Given this list of marker genes NDST1, CYTIP, ZNF24, AMIGO2, SELENOP, TSPAN32, LYPD6B, TGIF2, TIMP2, SLFN5, MGAT5, LRRC42, NIPAL1, PTEN, ITM2A, OAZ2, HIPK3, PIK3IP1, SH3PXD2A, TFCP2, UBE3A, SMARCC1, EXT1, SAMD8, AGO2, LIPA, MYB, IGSF23, BCL3, ADCY6, SOX4, LEF1, CYTH3, DUSP10, IKZF1, PTGIR, DLG4, AMER1, MTMR2, REEP1, CSNK1A1, TTC3, CD200, DGKD, TMEM108, USP28, ZBP1, MRPL30, TNS1, LPCAT3, ART4, ST8SIA1, PHF2, LARP4B, RIPOR2, TRIP12, SLC16A10, MARCKS, ACTN1, BCL11B, NUCB2, CALCRL, IL17RB, UBTD2, ATP6V1D, BTF3L4, ARHGAP29, TRPM1, MACO1, RRAGD, CNN3, CDC42EP4, OSBPL9, ZNF281 (NCBI Gene Id 23528), SATB1, GPR146, MTSS1, CAMK4, BEND5, ZNF629, TRIB2, PACSIN1, LDHB, SMO, SFMBT2, SMC6, PALS1, GPCPD1, ZNF22, TCF7, SPRED1, CSRNP2, SPSB1, BACH2 (NCBI Gene Id 653980), PPP1R3B, CHST15, GPRC5B, UBE2E2, GNB4, CD81, FOXP1, PLEKHG2, CIC, DAPK1 (death associated protein kinase 1), PMEPA1, KBTBD11, RAB3IP, AFF1, ATP8A1 (NCBI Gene Id 10396), PDK1, PLAUR (plasminogen activator, urokinase receptor), SLC16A5, ZEB1, MAP7, AFF3, IGFBP4, XKRX, PAK1, ALS2CL, C1orf74, CKAP4, PRICKLE1, GPR18, TGFBR3, RAMP1, GEN1 (NCBI Gene Id 348654), RASGRF2, TSPAN13, H3C14, EPHX1, MCL1, SPRED2, MED13, SULF2, ZCCHC12, CCDC30, RGS10, CUL3, DAPL1, TRIM56, THOC2 (NCBI Gene Id 57187), EPB41L1, NCOA3, TET1, SESN1, MYO10, ADA, PTK2, CREB1, MPP1, SORCS2, EGR3, CTSV, NRIP1, YEATS4, NFIX, RHOH, PPP1R3F, EGR2, STT3B, ST8SIA6, GABRR2, KCNMB4, RASGRP1, GPD2, VANGL2, HSDL1, MBNL2, DNTT, FAM210A (NCBI Gene Id 125228), ATP1B1, PPM1B, NAB2, RPL31, IFNGR2, CD163, ACVRL1, PDLIM4, ADH1C, ACVR1B, IFT25, NAV2, AMPD1, KDM6B, MMP15, GPR83, MBTD1, ATF7IP, CHDH, IL6ST, ZNF606, PDE4B, MYO6, OSBPL8, IZUMO1R, ARRDC3, ING1, TUBB2B, RFLNB, LRRC1, here is a description of the gene set: species: Homo sapiens T follicular helper (Tfh) cells play a pivotal role in germinal center reactions, which requires Bcl6 transcription factor. To analyze their relationships with other effector T cell lineages and their stability in vivo, we developed and analyzed a new Bcl6 reporter mouse alone or together with other lineage reporter systems. Assisted with genome-wide transcriptome analysis, we show substantial plasticity of T cell differentiation in the early phase of immune response. At this stage, CXCR5 appears to be expressed in a Bcl6-independent manner. Once Bcl6 is highly expressed, Tfh cells can persist in vivo and some of them develop into memory cells. Together, our results indicate Bcl6 as a bona fide marker for Tfh polarized program. from publication Liu X, Yan X, Zhong B, Nurieva RI, Wang A, Wang X, Martin-Orozco N, Wang Y, Chang SH, Esplugues E, Flavell RA, Tian Q, Dong C (PMID 22987803) Human Gene Set: GSE40068_CXCR5POS_BCL6POS_TFH_VS_CXCR5NEG_BCL6NEG_CD4_TCELL_DN Genes down-regulated in CXCR5+ BCL6+ follicular helper T cells versus CXCR5- BCL6- CD4+ T cells.